Given this list of marker genes Cox4i1, Tbl1xr1, Hdac3, Gm10053, Cox6c, Hbb-bs, Sin3a, Alb, Ncor2, Cycs, Blvra, Cox7b, Hbb-bt, Hba-a1, Med1, Cox6a2, Ncoa2, mt-Co2, Cox5a, Rxra, mt-Co1, Cox6b2, Carm1, Ndufa4, Chd9, Sin3b, Cox8c, Hmox2, Higd1c, Ncoa1, H13, Helz2, mt-Co3, Cox5b, Cox8a, Cox6b1, Cox7a2, Cox6a1, Tbl1x, Ppara, Smarcd3, Abcc1, Blvrb, Cox7a1 (cytochrome c oxidase subunit 7A1), Hmox1, Fabp1, Cox7c, Cox4i2, Cox7a2l, Tgs1, here is a description of the gene set: Cytoprotection by HMOX1 species: Mus musculus Mouse Gene Set: REACTOME_CYTOPROTECTION_BY_HMOX1